Given this list of marker genes TBC1D19, SLC16A1, LIFR, ADGRL2, ATM, RUNX2, NFAT5, NSMF, ENTREP3, KLRG1, LAMTOR3, SRL, ETFB, ADGRG3, CLNK, BTAF1, MAPK7, HCK, RHBDF2, LACC1, TCP11L2, CEP152, PRKAR2A, IL1RL1, TNFRSF14, PHKB, MDM1, SELENBP1, ENDOD1, IKZF2, ODC1, GKAP1, ASB2, BCL2A1, TARDBP, ATP1A1, STX11, TNFRSF19, SERPINB9, ARGLU1, B4GALT1, CENPH, PTK2, RNFT1, NBDY, ADAT2, TRIM11, INTS2, PCMTD1, MRPL52, ABCB4, THY1, COQ8B, ITGAE, MPO, IL18RAP, TNIP1, CRIM1, ADGRE5, FGD2, ARHGAP24, CDK4, RCN1, SLC9A8, SEPTIN3, NOD1, FAM53C, SDHAF1, IL6, KLRC1, NFKBIA, PARD6G, FLYWCH1, GFOD1 (Gfo/Idh/MocA-like oxidoreductase domain containing 1), PLSCR1, IL22, F2, FCER1A (Fc epsilon receptor Ia), WDR90, SLC6A13, F2R, AGPAT3, ROGDI, ATF3, DYNLL2, GNGT2, SKAP1, MYO1F, CPA3, ANKRD12, THOP1, KLHL24, FLACC1, SMAD3, WLS, S100A8, MLLT3, TNF, CLDN23, SLC23A2, AK8, SLIT3, CD247, MCRIP2, ACKR2, HACD3, GBP2, CIPC, PPAN, IKZF3, GCHFR, GZMA, DENND1A, NKG7, TRAP1, PRTN3, THYN1, LPCAT2, SAPCD1, LCMT1, RGS3, RAMP1, PTPN11, IER3, DAPK2, DTX1, DNAJB4, MYO6, ELOVL5, ATP5MC1, EARS2, FGGY, TLCD2, HSF2, VWF, IL1R1, NCSTN, SPACA9, MTX1, IKBKE, HDDC3, ART3, F13A1, ABTB2, IL18R1, NSG2, IL2RB, TMEM121, PLEKHA1, CYFIP1, MEF2A, FBXW10, TMEM87A, ATP9B, OAS1, NIPBL, TXK, FASLG, DIP2C, RNASEL, RBM45, TADA2A, SIPA1L1, KRIT1, ITGAL, LMNB2 (NCBI Gene Id 84823), S100A4, R3HDM1, TYK2, TNFAIP3, TPST2, CD300LF, UBA7, SEMA4A, IL10, SNX20, TM6SF1, MINDY3, VPS18, MAF, RNF17, PRKCQ, CD164 (CD164 molecule), PDE8A, SESN2, RAB8B, TARS2, ATP2B1, SOCS2, TBX21, CDH17, IL7R, FES, RMDN3, FAM168A, IRF7, CAPNS2, C19orf48P, ATP8B4, EGR2, here is a description of the gene set: During acute viral infections, naïve CD8+ T cells differentiate into effector CD8+ T cells and, after viral control, into memory CD8+ T cells. Memory CD8+ T cells are highly functional, proliferate rapidly upon reinfection and persist long-term without antigen. In contrast, during chronic infections, CD8+ T cells become “exhausted” and have poor effector function, express multiple inhibitory receptors, possess low proliferative capacity, and cannot persist without antigen. To compare the development of functional memory T cells with poorly functional exhausted T cells, we generated longitudinal transcriptional profiles for each. Genes down-regulated in CD8 T cells: naïve versus effectors at day 6 after acute infection with LCMV-Armstrong. from publication Doering TA, Crawford A, Angelosanto JM, Paley MA, Ziegler CG, Wherry EJ (PMID 23159438) species: Homo sapiens Human Gene Set: GSE41867_NAIVE_VS_DAY6_LCMV_ARMSTRONG_EFFECTOR_CD8_TCELL_DN